The following is a description of a gene set: NOTCH4 is co-expressed with DLL4 (Delta-4) and JAG1 (Jagged-1) in the vascular system. NOTCH4 can be activated by DLL4 and JAG1 when HMVECd cells (human primary endothelial cell line derived from neonatal dermal microvasculature) or HUVEC cells (human umbilical venous endothelial cell line) expressing recombinant mouse Notch4 are co-cultured with HMVECd or HUVEC cells expressing recombinant human or mouse DLL4 or mouse Jag1. Activation of NOTCH4 by DLL4 and JAG1 could not be reproduced when the mouse fibroblast cell line NIH 3T3 or human embryonic kidney cell line HEK293 was transduced with Notch4- or either Dll4- or Jag1-expressing vectors and used in co-culture experiments.<br><br>Signaling by NOTCH4, similar to other NOTCH family proteins, involves proteolytic cleavage of the membrane-bound NOTCH4 receptor and release of the NOTCH4 intracellular domain fragment (NICD4) into the cytosol. NICD4 traffics from the cytosol to the nucleus, where it acts as a transcription factor. Reactome Pathway: NOTCH4 Activation and Transmission of Signal to the Nucleus part of: Signaling by NOTCH4 species: Homo sapiens, and this is the list of marker genes: JAG1, DLL4, NCSTN, PSEN1, ADAM10, APH1A, NOTCH4, APH1B, PSENEN, PSEN2, YWHAZ